The following is a description of a gene set: studied in species Mus musculus Cluster 8: genes showing sustained pattern of down-regulation after knockdown of OPN by RNAi in the NIH3T3 cells (fibroblasts) transformed by activated HRAS. Activated forms of Ras family members are prevalent in many cancers where Ras mutants transduce signals essential for transformation, angiogenesis, invasion and metastasis. As a cancer progression model, we used NIH3T3 cells to explore the mechanism of Ras-induced tumorigenesis. Ras family mutants H-RasV12 and Rit79L strongly induced foci formation, while Rho family mutants RhoA-QL, Rac1-QL and Cdc42-QL were less effective. A comparison of downstream transcriptional targets of Ras and Rho family members using a 26 383 element cDNA microarray revealed that the osteopontin (OPN) gene exhibited the best correlation between magnitude of gene expression change and level of foci formation (r=0.96, P<0.001). In association with H-RasV12- and Rit79L-mediated transformation, foci secreted OPN protein and upregulated the OPN receptor CD44, suggesting the novel initiation of an aberrant OPN-CD44-Rac autocrine pathway. In support of this were the following observations. First, RGD-deficient OPN protein-binding activity was present in H-RasV12-transformed cells but not in control cells, and binding activity was inhibited by the CD44 blocking antibody. Second, foci formation, cell invasion and Rac activity were induced by H-RasV12 and inhibited by the CD44 blocking antibody. Third, foci formation by H-RasV12 was substantially reduced by a short interfering RNA (siRNA) specifically targeting OPN expression for knockdown. Fourth, H-RasV12-mediated transformation was not blocked by the GRGDS peptide, suggesting that OPN effects were not mediated by the integrins. Lastly, OPN knockdown affected the downstream expression of 160 '2nd tier' genes, and at least a subset of these genes appears to be involved in transformation. Indeed, four genes were selected for knockdown, each resulting in a disruption of foci formation and/or invasion. These results underscore the role of aberrant autocrine signaling and transcriptional networking during tumorigenesis. from publication Teramoto H, Castellone MD, Malek RL, Letwin N, Frank B, Gutkind JS, Lee NH (PMID 15516973) Mouse Gene Set: TERAMOTO_OPN_TARGETS_CLUSTER_8, and this is the list of marker genes: Nrcam, Homer2, P2rx3, 4933427D14Rik, Serpini1, Mapt, Nrgn, Spp1